The following is a description of a gene set: A cellular transport process in which transported substances are moved in membrane-bounded vesicles between endosomal compartments, e.g, between early endosome and sorting endosome. Mouse Gene Set: GOBP_VESICLE_MEDIATED_TRANSPORT_BETWEEN_ENDOSOMAL_COMPARTMENTS species: Mus musculus, and this is the list of marker genes: Emp2, Rab11a, Wdr91, Msn, Snx16, Rilp, Atg14, Mapk1, Mtmr2, Lmtk2, Ankrd27, Myo1d, Rdx, Hook3, Sorl1, Stx8, Nf2, Snf8, Ezr, Dennd10, Rab7, Fhip1b, Rab11fip3, Vps11, Dync1li1, Dab2, Snx3, Rab5a, Hook1, Sh3glb1, Dnajc13, Ighm, Snx12, Chmp3, Src, Pik3r4, Kif16b, Map2k2, Rab21, Ptpn23, Wdr81, Flna, Mapk3, Map2k1, Hook2, Pik3c3, Coro1a, Aktip, Becn1